The following is a description of a gene set: Binding to a mitochondrion targeting sequence, a specific peptide sequence that acts as a signal to localize the protein within the mitochondrion. Mouse Gene Set: GOMF_MITOCHONDRION_TARGETING_SEQUENCE_BINDING studied in species Mus musculus, and this is the list of marker genes: Tomm70a, Tomm40l (translocase of outer mitochondrial membrane 40-like), Tomm22, Tomm20, Timm22, Tomm20l